The following is a description of a gene set: Mouse Gene Set: GOBP_NUCLEOSIDE_MONOPHOSPHATE_PHOSPHORYLATION The process of introducing one or more phosphate groups into a nucleoside monophosphate to produce a polyphosphorylated nucleoside. species: Mus musculus, and this is the list of marker genes: Cmpk1, Ak5, Ak7, Ak2, Ak1, Dtymk, Cmpk2, Ak8, Ak4, Ak3, Ak6